The following is a description of a gene set: studied in species Homo sapiens Catalysis of the reaction: ATP + protein L-tyrosine = ADP + protein L-tyrosine phosphate by a non-membrane spanning protein. Human Gene Set: GOMF_NON_MEMBRANE_SPANNING_PROTEIN_TYROSINE_KINASE_ACTIVITY, and this is the list of marker genes: WEE2, TEC, PRKCD, ZAP70, PTK6, ITK, STK16, JAK2, DYRK1A, LYN, JAK3, CLK1, EIF2AK2, SRMS, PTK2B, BLK, TXK, MATK, ABL1, SYK, STYK1, TNK1, PTK2, PEAK1, JAK1, FES, TNK2, RIPK2 (NCBI Gene Id 8767), BMX, LCK, FER, FRK, MELK, BTK, ABL2, FYN, YES1, SRC, CSK, BAZ1B, PKDCC, FGR, HCK, TYK2, WEE1